The following is a description of a gene set: Human Gene Set: CAO_BLOOD_FLUMIST_AGE_05_14YO_1DY_DN studied in species Homo sapiens Genes down-regulated in blood 1d vs 0d in children (0.5-14y) after exposure to FluMist, time point 1D. Comment: ~80% of cohort were white, ~50/50 Female:male BACKGROUND: Live attenuated influenza vaccine (LAIV) and trivalent inactivated influenza vaccine (TIV) are effective for prevention of influenza virus infection in children, but the mechanisms associated with protection are not well defined. METHODS: We analyzed the differences in B-cell responses and transcriptional profiles in children aged 6 months to 14 years immunized with these 2 vaccines. RESULTS: LAIV elicited a significant increase in naive, memory, and transitional B cells on day 30 after vaccination, whereas TIV elicited an increased number of plasmablasts on day 7. Antibody titers against the 3 vaccine strains (H1N1, H3N2, and B) were significantly higher in the TIV group and correlated with number of antibody-secreting cells. Both vaccines induced overexpression of interferon (IFN)-signaling genes but with different kinetics. TIV induced expression of IFN genes on day 1 after vaccination in all age groups, and LAIV induced expression of IFN genes on day 7 after vaccination but only in children < 5 years old. IFN-related genes overexpressed in both vaccinated groups correlated with H3N2 antibody titers. CONCLUSIONS: These results suggest that LAIV and TIV induced significantly different B-cell responses in vaccinated children. Early induction of IFN appears to be important for development of antibody responses. from publication Cao RG, Suarez NM, Obermoser G, Lopez SM, Flano E, Mertz SE, Albrecht RA, García-Sastre A, Mejias A, Xu H, Qin H, Blankenship D, Palucka K, Pascual V, Ramilo O (PMID 24495909), and this is the list of marker genes: RORA, PCGF3, ATP9B, SASS6, MTCH2, PRDM10 (NCBI Gene Id 56980), MSRB3, MFSD12